Given this list of marker genes CDKN1B, MEN1, SDHD, CDKN2C, CDKN2B, CDKN1A, LMNA, ATRX, here is a description of the gene set: Human Gene Set: HP_PULMONARY_CARCINOID_TUMOR Pulmonary carcinoid tumor A malignant neuroendocrine tumor of the lung. According to histopathologic criteria, carcinoids are divided into four groups i.e. typical and atypical carcinoids, large cell neuroendocrine carcinoma and small cell lung carcinoma. species: Homo sapiens